The following is a description of a gene set: Mouse Gene Set: chr1A3 studied in species Mus musculus, and this is the list of marker genes: Defb44-ps, Gm25168, Gm5828, Gm5252, Terf1 (NCBI Gene Id 21749), Slco5a1, Gm28783, Gm25166 (predicted gene, 25166), Gm6060, Defb18, Gm28341, Gm7568, Tfap2d, Defb41, D030040B21Rik, Gm26273 (NCBI Gene Id 115485793), Gm28340, Ncoa2, Rbm6-ps1, Eloc, Gm7593, Prdm14, Gm5251, Rpl5-ps1, Msc, 4921511E07Rik, Gm4849, Mir6341, Crisp4, Gm9947, Gm28343, Sbspon, Gm28154, Rpl7, Gm28784, Crispld1, Jph1, Gm6216, Xkr9, Gm5250, Gm23169, Gm6075 (NCBI Gene Id 606716), Lactb2, Gm16070, Tmem70, Gdap1, Ube2w, Gm17644, Gm26345, Ly96, Tram1, Gm18775, Stau2, Gm10075, Gm5523, Trpa1, Idi1-ps5, 4930444P10Rik, Gm15825, Gm25227, Eya1, Smt3h2-ps4, Gm10566, Pi15, Gm17969, Gm7634, Gm17837, Rdh10, Gm2383, Kcnb2, Gm28153, Sulf1, Gm24075, Gm7690, Tfap2b